Given this list of marker genes OSBP, PCK2, UBE2J2, SETD2, TRPA1, NRXN1, GRIPAP1, SAE1, CCNE2, ENSA, ADCYAP1R1 (NCBI Gene Id 117), DPP10, ABCA12 (ATP binding cassette subfamily A member 12), UQCC2, LRIG2 (NCBI Gene Id 9860), RAMP3, CD2AP, CIB1, KIAA1614, OGT, MAPT, BYSL, GPC6, TTBK2, RABGAP1L, GHSR, HNF4A, SAPCD2, PRNP, SLC8B1, EPB41, SORL1, DYNLL1 (NCBI Gene Id 8655), STXBP4, HPCA, MAP1B, EPHA2, NOS1, PARK7, CORO2B, GLUL, SEC16B, EZR, BCL2L1, CD33, PICALM, CWH43, MACROH2A1, DLG1, TGFB1 (transforming growth factor beta 1), SLC30A8, RANGAP1, GPRC6A, MIR210, TNF, NPFF, CCDC88A, EIF4G1, RDX, BAD, PLN, RSAD2, TRPM5, IL12A, FERMT1, FEZ1, PPFIA1, PML, GPR27, UMOD, KHDC3L, UHMK1, DYNC1H1 (NCBI Gene Id 992), SSH1, C2CD2L, LMNA, ABHD17C, NOS2, TRPC3, NHLRC1, GNL3, TRIM67, CDK16, NSFL1C, TARDBP (TAR DNA binding protein), TM9SF4, CABP1, HDAC3, BMAL1, APC, HRAS, BARD1, DVL3, HLA-DRB1, NR1H4, RBP4, ABCG1, GPD1L, NECAB2, TYROBP, NMU, PPP2R5A, PKIG, GOPC, EP300, BICD1, EDNRA, DTX3L, TSG101, BDNF (brain derived neurotrophic factor), MARK3, TMBIM1, PHPT1, RPH3AL, SLC12A2, SMAD3, STK11, TMEM59, EDEM1, CSNK2A2, C9orf72, PTCH1, NEFH, GHRH, JAGN1 (NCBI Gene Id 84522), NUMA1, SREBF2 (NCBI Gene Id 6721), RALGAPA2, CRK (NCBI Gene Id 1398), TMEM53, CD200, SUMO3, CSNK1E, BAK1, SESN2, DOK7, MAP2K2, PER2, PRKCB, LZTFL1, LEP, TMEM30A, LYPLAL1, MTMR4, ZPR1, PLA2G4E, AFDN, TCAF1, IFNG, MIR19A, KCNK16, CCNE1, SLC16A1, NCBP2, RIPOR1, DYNLT2B, PUM2, RFX3 (regulatory factor X3), NACA, EPB41L5, GOLPH3 (NCBI Gene Id 64083), SIDT2, VEGFC, UCN3, ADCY8, ISCU, SNAPIN, CHP2, FRAT1, PKP1, VCP, CEP120, SERGEF, ERBB2, INHBB, BORA, MAPK14, MMP14, GIPR, FERMT2, GSK3A, NSD2, IPO5, LAMP1, TAX1BP3, GPR68, PRKAR1A, SCP2, NEDD4, ATP9A, USE1, NADK, NF1, ACHE, PKP3, HSPA8, SNAP25, INPP5F, STAC2, RBM10, YWHAE, RFX6, ZIC1, APBB1, TMEM108, ABI3, RNF139, GDI1, LCN2, SUMO4, EPO (erythropoietin), KLF7, ZDHHC2, ATP2B4, ANKRD1, PRKAA1, ARHGEF5, SWAP70, APOD, HIF1A, SEPTIN2, SYTL4, BAIAP3, GJA5, NLRP5, CCT7, FUT10, CAMK1, CEP295, MIR199A1, PPP1R9B, PGAP1, MIR766, ATP2A1, GCC2, ANXA2P2, TNNC1, B3GAT3, RAN, ITGA3, CSRP3, ADCYAP1, MTNR1B, CNTLN, SYT11, TGFB2, HHEX, BNIP3L, YOD1, OAZ2, TMEM30B, ADRA2C, GNAO1, XBP1, ERP29, MIR128-1, DNAJB6, MTCL1, PYHIN1, VPS28, WWC1, PLA2G6, CALCA, MIDN, PTPN9, ARIH2, PPP1CC, CCT8, KIAA0586, MAPK1, DMAP1, ADRA2A, RTN4, NR1D1, PRKG2, TMED2, FKBP1B, ARHGEF16, ARHGAP44, ATP13A2, GAS6, SLN, REST, EPB41L2 (NCBI Gene Id 2037), TGFB3, CARTPT, TOR1A, MIR146A, VPS4A, NUS1, GPM6B, BORCS5, ITGAM, FLNA, ARHGDIA, WNK1, WNT5A, ADORA2A, ZDHHC5, BLK, ZC3H12A, MAVS, TRIM22, UBE2J1, PARD6A, ZBED6, ZFP36, TMBIM6, GABARAP, HAX1, SIRT3, FOXO1, JAK1, TLR2, BCL2, MCU, RNF31, P2RX2, RAP1A, STX10, HDAC6 (histone deacetylase 6), LRRC15, ALOX5, F2RL1, STAC, SCFD1, SHISA6, PSEN1, ITPR1, KIF2C, DNAJC13, UNC13B, PTPN14, MDM2 (NCBI Gene Id 84825), IRS1, CEP131, NUP62, P3H1, TRPM4, SLC25A22, FFAR1, EHD2, PFKFB2, CLOCK, PMFBP1, SP100, DERL2, FCER1G, ACTN2, FGG, HCLS1, EPHB2, GPC1, INS, SNX33, CCT4, WDPCP, HTRA2, YWHAB, ENTR1 (endosome associated trafficking regulator 1), PIK3R2, DZIP1L, RUFY3, CAPN10, UFM1, VRK1, MGAT3, ITGB2, IDH2, RHBDD3 (NCBI Gene Id 25807), EDN1, TMEM35A, TPR, IER3IP1, TTC21B, SLC51B, GRIN1, NMT1, MTMR2, C1QTNF12, TMED10, NR1H2, IPO7, CDK5RAP3, PARD6G, CTNNB1, PIAS4, REEP2, WNK4, TMEM132A, ACSL4, C1QTNF3, APOE, STX1A, TM7SF3, HSP90AA1, TFAP2B, NUMB, PRKCE, ADIPOQ, WNT3A, COMMD1, USP7, PKDCC, REEP6, GPSM2, CAMK2G, KRT20, CD247 (CD247 molecule), DENND10, NUP214, EMD, RSC1A1, MIEF2, PDZK1, RHOQ, RAB8A, CREBBP, TFRC (transferrin receptor), SREBF1, CACNA2D2, HSP90AB1, PDCD10, FNTA, ANK3, DAB2, APP, MMD2, C2CD5, SYBU, FRAT2, NKD2, SUFU, WNT7A, ACTB, DDRGK1, TOMM70, RINT1, MRAP2 (NCBI Gene Id 353265), ABCC8, GNAS, ERBB4, NR1H3, PRKCA, KIF5B, ADAM10, VAMP8, UBXN2B, PDX1, PDPK1, F2R, CACNG2, B9D1, NCKAP1, CLN3, PFKM, CLSTN3, ANGPT1, CD81, TCF7L2, CRYAB, PRKCI, RAB38, PCNT, TRIM5, KCNN4, PDE8B, LRP4, NSUN2, NUP153, SLC35D3, TCIRG1, TUNAR, CHP1, CASR, SHH, MYBPC3, LEPROT, CTNND1, TMEM231, GLUD1, MIR520E, ORAI1, PLK1, GNL3L, CDH1, TERF1, PPM1A, CHRM1, PRKCD, CTNNA1, IL13, ABAT, F2, VEGFA, TREM2, ABCA7, CEP135, AAK1 (NCBI Gene Id 652453), REEP5, APBB3, PPIA, TYK2, CPLX1, VPS11, ZDHHC8, VSNL1, SRC, RIC3, CACNB4, MCRS1, EFNA5, DVL1, CAMK2D, GNAZ, CAV3, UBAC2, RSL1D1, ITGB1BP1, RAB11FIP3, FOXA2, OTUD7B, AKAP8L (NCBI Gene Id 26993), ARHGAP8, PPM1F, CEMIP, LRP5 (NCBI Gene Id 8058), DRD3, ZFAND1, CLTC, INPPL1, EPHA5, MRAP, CNST (NCBI Gene Id 163882), YWHAZ, HPS4, CCT5, PINX1, SPAG5 (sperm associated antigen 5), PPARG, AKT1, TRIM40, CENPQ, UCP2, PGRMC1, NEUROD1, BMP8A, ANXA13, DPH3 (diphthamide biosynthesis 3), NKX6-1, DSG3 (NCBI Gene Id 1830), OR51E2, VCPIP1, ATG13, FZD5, AACS, JAK2, GPC5, TRIM46, SIX1, CNPY4, P2RX7 (purinergic receptor P2X 7), POLR1A, ABHD17A, PRKN, NRDE2, SPIDR, STX4, WNK3, SPTBN1, LAMTOR5, RER1, NDUFAF2, GNAI1, SAA1, SH3GLB1, BAG4, CDH2, VTI1B, PPID, PICK1, RAB11FIP1, RAC1, MLXIPL, TRAPPC12, SOX4 (NCBI Gene Id 6659), SNCA, FGA, VIP, CROCC, CCDC66, MX2, CYP51A1, VPS26B, FRRS1L, NLGN2, DSG2, LIMK2 (LIM domain kinase 2), STX18, ANG, CRIPT, SLC7A11, C11orf65, APPL1, YIPF5, FGB, GBF1, UBE2G2, ITGB3, ABHD17B, HYAL2, PPARD, CSK, ACSL3, GSK3B, MAP2, SIRT4, FUT11, ZFP36L1, TERT, XIRP2, RASSF5, OOEP, ERLEC1, NGFR, USP36, SIRT6, TTC8, RAB11FIP5, YAP1, HMGCR, WLS, CYLD, USP17L2, MYO1C, DAG1, SORBS1, PLS1, PPP1R12A, IL1A, IGF1, TOMM7, SUMO1, IL6 (interleukin 6), CRH, ASPH, MYO18A, SNX3, CRYZL2P-SEC16B, EI24, DNAJB2, MFHAS1, FZD9, RAB11A, ZDHHC7, ATP2C1, MIR17, ABLIM3, NKX3-1, TNFAIP6, RAB9A, TMEM97, HADH, HCAR2, NVL, CLDN18, ARF6, DZIP1, PRKCH, DDX39A, CDK5R1, BBC3, GLI3, SELENOK, TTN, GPC3, MIR30C1, PTPN1 (protein tyrosine phosphatase non-receptor type 1), CEP250, PRKAA2, LARP7, TRIM25, MPC2, LYPLA1, CCT2, BMP6, MARK4, RIPOR2, ERGIC3, TRIM28, DNAJA1, PLK3, GCK, CTDSPL2, MEAK7, FBXO4, CEP72, GAPVD1, BMPER, ASTN2, NDFIP1, SH3TC2, LGALS3, FKBP1A, SVIP, IQSEC2, ISL1, MICALL2, PTP4A3, XPO1, CPT1A, KCNB1, LMAN1 (NCBI Gene Id 3998), STX8, EIF2AK3, MDFIC, PAK1, ABCA2 (NCBI Gene Id 23153), MIR19B1, G6PC2, TRH, RAB11B, HUWE1, SLC5A3, CCT3, KAT7, UBL5, FARP1, RAP1GDS1, LRP1, MTOR, TRAF6, BAX, SLC1A1, TRIM8, FFAR2, PIAS1, PTPN23, RAB14, EPHA3, TBC1D20, BAG3, GPLD1, SIAH3, THOC2, STOM, DRD4, WWTR1, MAGED1, ARV1, LNCPRESS1, HSPA1L, KIF20B, DRD2 (dopamine receptor D2), WRAP53, KDM1A, TXN, SLC30A1, NPM1 (nucleophosmin 1), PECAM1, NNAT, AR, MEPCE, UBE2D3, STX6, STAC3, MLC1, GPC4, CRYAA, DMTN, SYT7, MYLK2, PIN1, CCT6A, MYOM1, NUP58, CD38 (CD38 molecule), PRR5L, TLR4, DNM1L, MYRIP, GAS1, LATS1, CDK5, VAMP4, RAPGEF3, RANGRF, GDI2, TENM1, CHGA, ICE1, TMEM98, OPRM1, CELA2A, KCNA5, SYCP1, PKIA, STX7, GHRL, PARD6B, PARP9, ARFIP1 (NCBI Gene Id 27236), PSMD9, GPER1, IRS2, P2RX5, NDEL1, EPB41L3, FAM3D, RHOU, CDKN2A, CRKL, RAPGEF4, PIK3CA (phosphatidylinositol-4,5-bisphosphate 3-kinase catalytic subunit alpha), EPM2A, PLEKHM2, FBXW7, AP2M1, DERL3, CD4, AP2B1 (NCBI Gene Id 163), ANXA2, MAPK8, KCNAB2, AMOTL2, EHD1, ARHGDIG, PCSK9, IL1B, CAMK2B, OLFM1, KCNJ11, PLA2G3, DHX36, RNF4, MAPK3, TP53INP2, VAMP2, IWS1, BVES, KHDRBS1, PLA2G1B, MIR223, GAS8, GCG, NDRG4, UBE2L3, SLC9B2, GSN, CAMK2A, ATP5IF1, OXCT1, ANO1, PTPN11, PINK1, LDLRAP1, SSTR5, ADAM9, CD36 (CD36 molecule (CD36 blood group)), MIR148A, SLC2A2, INPP5E, CHMP3, NF2, PIM3, BMP4, VPS35, GIP, USP8, ACD, TESK1, PRKACA, BSG, VCL, INPP5K, LATS2, ITGB1, CCN3, MESD, SEC24B, OS9, RAB23, PPP3CB, RIOK2, MAP2K1, P2RX3, NDFIP2, SMO, DCLK2, UBR5, INSIG1, SEC24A, CAV1, SEPTIN8, ANP32B, STRIT1, SRI, MYCBP2, KRT5 (NCBI Gene Id 3852), MYH10, GPC2, MIR520B, ADTRP, SNX12, GBP1, CTSD (cathepsin D), SFN, MIR185, HAP1, PCM1, IFI27, MIEF1, CFTR, AAAS, SIX4, ORMDL3, BAP1, GOLPH3L, YWHAG, LCP1, RAB29, CENPJ, NR0B2, ILRUN, CPSF6, TRIM17, RAB21, CDK1, CFL1, F2RL2, CLIP3, ADCY10, UBL4B, ECT2, OAZ1, DHX9, CARD10, RUFY4, KCNE1, SHISA7, CHRM3, MMD, GPR137B, WWP2, PRKD1, MAP1A, ALKBH5, LRRK2, EIPR1, JUP (NCBI Gene Id 3728), NMD3, GZMB, LAMTOR1, RHBDF1, FRMD4A, AKT2, SQSTM1, OAZ3, AKAP5, LRRC8A, ACVR1C, HFE, EXPH5, MIR29B1, SIRT7, TCP1, EDEM2, DNAJC1, LYPD1, ROCK2, WASL, DOC2B, GNA11, BCAP31, EGF, PLCB1 (phospholipase C beta 1), IL12B, NEAT1, PARL, NFKBIA, RAC2, BTF3, XPO4, ENY2, PIK3R1, CCL5, AGR2, ADCY5, FYN, MIR27B, FAM76B, P2RX4, NEDD9, MISP (mitotic spindle positioning), NPEPPS, RHBDF2, CELSR2, RBM22, ZMYND8 (zinc finger MYND-type containing 8), MRLN, ATCAY, ADAM8, RAB11FIP2, HNRNPAB, SYT4, PRP4K, MSN, IER3, NETO2, PFKL, BRSK2, UFL1 (NCBI Gene Id 23376), EPS15, ANKRD13A, PID1, EFCAB7, CEP290, ARHGAP1, SIN3A, VIL1, TCAF2, PARP1, GLIS2, RHOG, SERP1 (stress associated endoplasmic reticulum protein 1), CDK9, STX3, TRIM58, NEO1, MIR93, LILRB4, SLC26A4, MIR199B, LZTS2 (leucine zipper tumor suppressor 2), TRIM29, RACK1, SPI1, RBM4, NEDD4L, EGFR, here is a description of the gene set: studied in species Homo sapiens Any process that modulates the frequency, rate or extent of a process in which a cell, a substance, or a cellular entity is transported to, or maintained in a specific location within or in the membrane of a cell. Human Gene Set: GOBP_REGULATION_OF_CELLULAR_LOCALIZATION